Given this list of marker genes Chd1, Helb, Fbh1, Atrx, Rfc4, Nav2, Mcm8, Rfc2, Dqx1, Hfm1 (HFM1, ATP-dependent DNA helicase homolog), Gtf2f2, Helq, G3bp1, Rad54l2, Upf1, Zgrf1, Dhx30, Mcm9, Wrn, Ddx11, Mcm6, Mcm2, Mcm5, Ruvbl1, Dscc1, Chd8, Pif1, Polq (polymerase (DNA directed), theta, NCBI Gene Id 77782), Ercc3, Rad54l, Chtf18, Rad50, Anxa1, Smarcad1 (NCBI Gene Id 13990), Chd5, Xrcc5, Mcm4, Rtel1, Dhx9, Brip1, Ighmbp2, Ercc2, Chtf8, Chd2, Chd9, Twnk, Ascc3, Supv3l1, Blm, Mcm7, Ruvbl2, Rfc5, Dna2, Recql, Rfc3, Ercc6l (excision repair cross-complementing rodent repair deficiency complementation group 6 like), Xrcc6, Chd7, Fancm, Mcm3, Chd4, Recql4, Zranb3, Ddx3x, Mre11a, Dhx36 (DEAH-box helicase 36), Recql5, Chd6, Rad51, Sub1, Wrnip1, D1Pas1, Chd1l (NCBI Gene Id 68058), here is a description of the gene set: Unwinding of a DNA helix, driven by ATP hydrolysis. studied in species Mus musculus Mouse Gene Set: GOMF_DNA_HELICASE_ACTIVITY